The following is a description of a gene set: part of: APC/C-mediated degradation of cell cycle proteins electronically inferred by orthology from the curated human pathway Reactome Pathway: Regulation of APC/C activators between G1/S and early anaphase This event has been computationally inferred from an event that has been demonstrated in another species.<p>The inference is based on the homology mapping from PANTHER. Briefly, reactions for which all involved PhysicalEntities (in input, output and catalyst) have a mapped orthologue/paralogue (for complexes at least 75% of components must have a mapping) are inferred to the other species. species: Mus musculus, and this is the list of marker genes: Fzr1 (fizzy and cell division cycle 20 related 1), Ube2e1, Cdk1, Rps27a, Ubb, Cul1, Cdc23, Ube2s, Ube2c, Ccna1, Anapc2, Ube2d1, Anapc15, Plk1, Anapc7, Ccnb1, Mad2l1, Anapc10, Cdc26